The following is a description of a gene set: species: Homo sapiens Genes predicted to be targets of miRBase v22 microRNA hsa-miR-10523-5p in miRDB v6.0 with MirTarget v4 prediction scores > 80 (high confidence targets). from publication Chen Y, Wang X (PMID 31504780) Human Gene Set: MIR10523_5P, and this is the list of marker genes: ROBO1, TAB3, NUP58, PDS5B, AMOTL1, ZNF675, NLGN4X, RAB21, UBE2F, H1-8, RBM12, PRICKLE2, CNOT2, PPP1R3A, TUSC3 (NCBI Gene Id 7991), TUBGCP3, LILRA1, DPH6, TAC1, TTC9, RSBN1, RPS6KB1, PPP1R8, PSMD12, VRK1, GMEB1, TNFSF9, VPS35, UBE2G1, TLK1, PTPRC, ST18, NOG, PAX7, MMP28, PPIG, MYSM1, GABRA4, TEAD1, ALDH1A3, DEPTOR, ENPP1, SLC25A40, PPP2R5E, MAP3K2, EWSR1, SLC25A21, DYRK1A, CPB2, RAD23B, BEND4, CCN3, USP9X, BMP1, EIF1AY, TMEM209, HYCC2, FUBP3, USP8, VEZF1, AFDN, NUMB, HNRNPH1, MRGPRX3, FAM200C, GART, ZNF148, FOXF1, LMLN, PAK2, PGRMC1, ASIC5, ANKH, SHISA2, FRS2, DCP1A, ZNF704, GNPNAT1, RNPS1, PTEN, QKI, ANKRD36C, PDCL, C8orf34, MAP3K7, DNHD1, ASGR2, AHNAK, WAPL (NCBI Gene Id 23063), RILPL2, ZNF207, NAV2, MDH2, FOXG1, RBM22, SMUG1, PAN3, ODAM, ATP9A, ZNF521, CCT5, SLC8A3, USP24, ARAP2, BLTP3B, LRRC3B (NCBI Gene Id 116135), SLX4IP, SLITRK3, RWDD2A, AFAP1L2 (actin filament associated protein 1 like 2), PRDX3, KRT10-AS1, PTBP3, PAPOLG, FOS, U2SURP, SSBP2, URM1, STXBP5, FOXN2, ASAP2, COX6C, DCAF13, TMPRSS15, ACTC1, PRKCE, ZC3H12A, SH3GL3 (SH3 domain containing GRB2 like 3, endophilin A3), RAB14, LCOR, USF3, BDH2, MAB21L2, CSMD1, PKN2, MTCL3, OPRK1, LAMTOR3, TCF12, CYP20A1, ZFP90, PTS, NALCN, GTF2E1, R3HDM1, TM4SF1, RELN, MFAP3L, SLC6A17, IL1RAP, HIPK3, PACC1, WTAP, FAM13B, B4GALT6, SOST, COL21A1, DNAL1, ZFP42, NAA16, BACH2, DLGAP1, SAXO1, NELFA, PTPN4, SUMO2, DBR1, ZNF268, PPARGC1A, ARIH1, SATB1, VAPB, NFYB, EPG5, TTF2, SIKE1, SEPTIN14, FUBP1, PTCH1, IKBIP, WDFY3, OSBPL3, DMRT1, ZNF236, HDDC2, UTP3, GALNS, SLC12A8, ZMYND8, CDH11, YOD1, SNTB2, POU2F1, IL22, RABGAP1L, RPP30, FEM1C, MARCHF5, TPST1, SDC2, TBL1XR1, RFTN2, SCML2, SCYL2, HMG20A, ACAP2, SNX2, HGF, SMCHD1, KLF8, ARHGAP28, ID4, LSM8, ANKRD12, ASPH, MRPS10, PXDN, FNDC3B, HNRNPK (NCBI Gene Id 3190), KCNJ5-AS1, SLC4A4, STARD7, TLE4, FYN, POU2F2, NR2E1, WWTR1, LRRCC1 (leucine rich repeat and coiled-coil centrosomal protein 1), POGZ, GSK3B, RESF1, TAF9, STRAP, MED12L, PPFIA1, HMGXB4, SACM1L, ADAMTS6, PCDH19, CREBRF (NCBI Gene Id 153222), RFX3, NGDN